The following is a description of a gene set: Human Gene Set: GCACCTT_MIR18A_MIR18B species: Homo sapiens Genes having at least one occurence of the motif GCACCTT in their 3' untranslated region. The motif represents putative target (that is, seed match) of human mature miRNAs hsa-miR-18a and hsa-miR-18b (v7.1 miRBase)., and this is the list of marker genes: ANKRD50, ATXN2L, NCOA1, GLRB, TMEM248, PIAS3, SON, FAM136A, GAB1, CREBL2, GIGYF1, PURB, PHF2, TRIM2, ARL15, RABGAP1, CLIP3, SOCS5, ADD3, CTDSPL, NAV1, MDGA1, NR1H2, CCDC88A, KDM5B, SNURF, RAB11FIP2, DIP2C, XYLT2, UBE2Z, CLK2, TNRC6B, SORBS2, PRKACB, ATXN1, SLC17A9, RAB5C, SH3BP4, GRHL2, ZBTB47, ALCAM, CRIM1, SAR1A, SMAP2, ESR1, AEBP2, FNBP1, ASXL2, PHF19, UBTD2, FRMD4A, LIN28A, PDZD2, ZBTB4, ADAMTS13, TRIB2, MESP1, BTG3, HMBOX1, TEX2, KIT, ZBTB44, BHLHE22, PTGFRN, SMAD2, PACSIN1, RHOT1, NFAT5, FCHSD2, ARHGEF5, NR3C1, SIM2, HIF1A (NCBI Gene Id 3091), IGF1, ZNF704, KMT5A, EPB41L1, CSRNP3, NAA50, BRWD3, CDK19, PRICKLE2 (NCBI Gene Id 166336), CLASP2, REXO2, STK4, IRF2, ZFP36L1, PSME3IP1, PSD3 (pleckstrin and Sec7 domain containing 3), MEF2D, PHF20L1, TARDBP, AKR1D1, CCDC106, SUCO, ZNF367, GCLC, IGF2BP2, KLHL20, CAMSAP2 (NCBI Gene Id 23271), TRIOBP, ETV6, MAP7D1, CDC42, C11orf87, VMA21, CCN2, PARP6, RAB1B (RAB1B, member RAS oncogene family), KDM2A, EHMT1, WSB1, NEDD9, DPP10, RUNX1, MACIR, MAN1A2, TSHZ3, HSF2